Given this list of marker genes ATP6V1B2, TK2, CHSY1, PTPN11, GJB2, KMT2D, TRIOBP, COL1A2, ALMS1, GJB6, GPSM2, BRAF, RAF1, VSX1, here is a description of the gene set: species: Homo sapiens A severe form of hearing impairment. Severe hearing impairment Human Gene Set: HP_SEVERE_HEARING_IMPAIRMENT